Given this list of marker genes FBXW7, IGFBP2 (NCBI Gene Id 3485), SLC9A1, PRRC2C, PLSCR1, MXD3 (NCBI Gene Id 83463), RAD54B, CHST1, SOS1, TDO2, PTPN14, CDYL, MARCKS, SAP25, SIX2, ADGRB2, FBLN1, SCCPDH, TRAIP, RAPGEF3, HELLS, ENO2, ELOVL6, SEMA3F, GNG10, ABCC5, NMU, GNB5, WLS, KIAA0319L, TLK1, RAD1, HLA-H, OBSL1, PSMB8, ACTN2, CTNND2, SUZ12, KIF5C, EVL, PLCB1, DSP, LPIN2, PHLDA2, EDN1, DTX3, NR2F1, EPS8, ABLIM3, PDE4B (phosphodiesterase 4B), CDKN1A, CDC25A, BEX3, SLC35D1, ATAD2B, PAX9, RBMS1, TRA2A, PTP4A1, SEPTIN8, BRIP1, SLC29A3, RFTN1 (raftlin, lipid raft linker 1), NSD2, CDK1, MAST4 (microtubule associated serine/threonine kinase family member 4), ANP32E, TBRG4, AKAP9, DUS2, HERC6, IFT122, TFF1, KMO (kynurenine 3-monooxygenase), PPARD, RANBP3, TMEM106C, CASP7, IDH2, RTN1, PPP4R3A, SERPINH1, CSH2, ANXA6, TMEM123, SEMA3C, SUSD4, C4orf19, CCNE2, BCL7A, PRKCD, E2F8, BLMH, GATA3, CYFIP2, RRAS, DGCR11, RAB15 (RAB15, member RAS oncogene family), THBS1, SIPA1L1, SNX7, ARHGEF3, LRP6, EPHA4, ARNT, CDC42, DCLK1 (doublecortin like kinase 1), MCM5, IFITM3, EPB41L4A, APOBEC3B, TAF9B, PAQR4, STS, HLA-A, EPB41L2, ANXA9, PSIP1, PCOTH, ZNF322, RAD54L, ZFP36L2, QKI, ABCB9, HCFC1R1, SAMHD1, MGP, EFNB3, PDZRN3, RAD51D, KREMEN2, CYBRD1, CKB, SUPT6H, ITPR1, FAM110B, RIBC2, ARG2, ASAP3, EFNB2, DHFR, TRAF2, PDE6D, PIDD1, HEATR6 (HEAT repeat containing 6), FYB1, MCM4 (minichromosome maintenance complex component 4), PLK4, WSB1 (WD repeat and SOCS box containing 1), NCDN, MPP1, NUP160, SZRD1, ASPH, CDC42EP2, ZNF93, SMAD6, IRS1, CRABP2, PRKACA, TCAF1 (TRPM8 channel associated factor 1), CACNA1D, SGTA, DST, TUBB2A, RRM2, CHAF1A, GPC1, CDKN2C, ARVCF, ERF, EEF1A2, PCBP4, IGFBP3, IFITM1, CXCR4, MTF2, TIAM1, BAMBI (NCBI Gene Id 25805), SMAD3, PRSS8, DUSP4, DHRS3, MCAM, PPDPF, TNC, SLC25A14, RPS2, PLEKHA6, ARHGAP35 (NCBI Gene Id 79266), PRAF2, SP110, PIN1, FBXL7, ZPR1, TSC22D2, MN1, PEX5, PYCARD, STOM, PALLD, PRDM2, DUSP6, NACA4P, SNPH, CPOX, ATXN1, PHC1, IFI30, VTCN1 (V-set domain containing T cell activation inhibitor 1), ATP5F1D, RAI14, UBL3, RGS10, LPCAT4, PELI2, TRMT61A, TRIM23, HP1BP3, PLPP2, VDR, ZDHHC13, GASK1B, TOR1AIP2, SMYD5, IGFBP5, LTBP1, STAG2, AMIGO2, YPEL1, TPT1, FKBPL, PLXND1, TINAGL1, TRAF5, PLOD2, MED13L, ZFR, KHK, NOC4L, SLC27A2, RECQL4, SSBP2, here is a description of the gene set: Little is known of the underlying biology of estrogen receptor-negative, progesterone receptor-negative (ER(-)/PR(-)) breast cancer (BC), and few targeted therapies are available. Clinical heterogeneity of ER(-)/PR(-) tumors suggests that molecular subsets exist. We performed genome-wide expression analysis of 99 primary BC samples and eight BC cell lines in an effort to reveal distinct subsets, provide insight into their biology and potentially identify new therapeutic targets. We identified a subset of ER(-)/PR(-) tumors with paradoxical expression of genes known to be either direct targets of ER, responsive to estrogen, or typically expressed in ER(+) BC. Differentially expressed genes included SPDEF, FOXA1, XBP1, CYB5, TFF3, NAT1, APOD, ALCAM and AR (P<0.001). A classification model based on the expression signature of this tumor class identified molecularly similar BCs in an independent human BC data set and among BC cell lines (MDA-MB-453). This cell line demonstrated a proliferative response to androgen in an androgen receptor-dependent and ER-independent manner. In addition, the androgen-induced transcriptional program of MDA-MB-453 significantly overlapped the molecular signature of the unique ER(-)/PR(-) subclass of human tumors. This subset of BCs, characterized by a hormonally regulated transcriptional program and response to androgen, suggests the potential for therapeutic strategies targeting the androgen signaling pathway. from publication Doane AS, Danso M, Lal P, Donaton M, Zhang L, Hudis C, Gerald WL (PMID 16491124) Genes down-regulated in MDA-MB-453 cells (class A ER(-) breast cancer) after exposure to the androgen R1881. species: Homo sapiens Human Gene Set: DOANE_RESPONSE_TO_ANDROGEN_DN